Given this list of marker genes HS3ST4, HS3ST3B1, HS3ST1, HS3ST2 (NCBI Gene Id 9956), HS3ST5, HS3ST3A1, HS3ST6, here is a description of the gene set: Catalysis of the reaction: alpha-D-glucosaminyl-(n) + 3'-phosphoadenylyl sulfate = 3-sulfo-alpha-D-glucosaminyl-(n) + adenosine 3',5'-bisphosphate + H+. species: Homo sapiens Human Gene Set: GOMF_HEPARAN_SULFATE_GLUCOSAMINE_3_SULFOTRANSFERASE_ACTIVITY